Given this list of marker genes P2RY12, SYNJ2BP-COX16, H3P16, AUNIP, CD83, SLX1B-SULT1A4, ZNF485, S100P, APLF, LINC01001, KDM4A-AS1, here is a description of the gene set: Human Gene Set: HOEK_MONOCYTE_2011_2012_TIV_ADULT_1DY_UP studied in species Homo sapiens from publication Hoek KL, Samir P, Howard LM, Niu X, Prasad N, Galassie A, Liu Q, Allos TM, Floyd KA, Guo Y, Shyr Y, Levy SE, Joyce S, Edwards KM, Link AJ (PMID 25706537) Genes up-regulated in monocyte 1d vs 0d in adults after exposure to 2011-2012 trivalent inactivated vaccine (A/California/7/09 (H1N1), A/Perth /16/2009 (H3N2), B/Brisbane/60/2008), time point 1D. Comment: Up-regulated DE RNA transcripts (up >= 1.5x) shared between both TIV-vaccinated donors Systems biology is an approach to comprehensively study complex interactions within a biological system. Most published systems vaccinology studies have utilized whole blood or peripheral blood mononuclear cells (PBMC) to monitor the immune response after vaccination. Because human blood is comprised of multiple hematopoietic cell types, the potential for masking responses of under-represented cell populations is increased when analyzing whole blood or PBMC. To investigate the contribution of individual cell types to the immune response after vaccination, we established a rapid and efficient method to purify human T and B cells, natural killer (NK) cells, myeloid dendritic cells (mDC), monocytes, and neutrophils from fresh venous blood. Purified cells were fractionated and processed in a single day. RNA-Seq and quantitative shotgun proteomics were performed to determine expression profiles for each cell type prior to and after inactivated seasonal influenza vaccination. Our results show that transcriptomic and proteomic profiles generated from purified immune cells differ significantly from PBMC. Differential expression analysis for each immune cell type also shows unique transcriptomic and proteomic expression profiles as well as changing biological networks at early time points after vaccination. This cell type-specific information provides a more comprehensive approach to monitor vaccine responses.